The following is a description of a gene set: species: Homo sapiens Somatic mutations or rearrangements in genes involved in telomere maintenance enable immortalization of cancer cells either through upregulation of telomerase activity or through activation of alternative lengthening of telomeres (ALT). Germline mutations in telomere maintenance genes lead to telomere syndromes, such as dyskeratosis congenita (DC) and Hoyeraal-Hreidarsson (HH) syndrome, characterized by impaired ability to maintain telomere lengths during growth and development, leading to abnormally short telomere lengths and genomic instability that affects multiple organs and is associated with increased risk of certain cancers. Reactome Pathway: Diseases of Telomere Maintenance part of: Diseases of mitotic cell cycle, and this is the list of marker genes: ATRX, DAXX